The following is a description of a gene set: Human Gene Set: GOBP_REGULATION_OF_CELL_PROJECTION_ASSEMBLY Any process that modulates the rate, frequency, or extent of cell projection assembly. species: Homo sapiens, and this is the list of marker genes: MYO3B, YAP1, ZMYND10, RAP1GAP, NRXN1, LUZP1, CCP110, PALM, RABGAP1, IFT140, P2RX4, EPHA2, ACTR2, HAP1, CYLD, CLRN1, AKIRIN1, TBC1D7, SYNE2, MNS1 (NCBI Gene Id 55329), TBC1D19, MAP4, DMTN, USP6NL, DCDC2, GAP43, RDX, CARMIL2, PODXL, WDPCP, ADAMTS16, COBL, ARAP1 (ArfGAP with RhoGAP domain, ankyrin repeat and PH domain 1), P2RX7, SEPTIN9, CTTN, C15orf62, DYNC2LI1, TBC1D30, EPS8L2, EPS8, AGRN, ANLN, PLPPR5, TBC1D21, TBC1D17, DPYSL3, ODF2, HRG, FUZ, RHOG, FNBP1L, RAB11A, RALA, BBS4, LIMA1, DOCK11, TBC1D20, MIR196A1, ARHGAP35, TBC1D10B, NRP1, WASL, TWF1, TBC1D10A, CROCC, AVIL, CCDC88A, KANK1, NDEL1, TBC1D2B, RAB3IP, ACTR3, FMR1, ARHGAP44, SRF, TRIM32, MAK, TWF2, HSP90AA1, PFN1, CCL19, MPHOSPH9, RAB17, MAPK15, EPS8L3, RAC1, WASHC1, WDR44, CDC42EP1, TBC1D24, KIF24, TBC1D16, EVI5 (ecotropic viral integration site 5), ARPC2, CFL1, SEPTIN7, PIK3CA, ATG5, TBC1D13, EVI5L, FER, CDC42EP3, TESK1, RP1, CDC42, SAXO1, HTT, CLN3, LPAR1, DEF8, DYNLT2B, TBC1D22A, ODAD3, PLEK2, IFT88, TBC1D9B, AUTS2, NEURL1, PLXNB3, ATP8B1, TENM1, ICAM1, CDC42EP2, SRC, TTBK2, PIK3R1, TBC1D10C, TBC1D14, MTOR (mechanistic target of rapamycin kinase), CENPJ, TRPM2, P2RY12, FSCN1, FAM98A, TENM2, WRAP73, OCLN, FAM110C, TGFBR1, CDC42EP5, PLEKHM1, RAC2, F2RL1, FRMD7, ZMYND8, NOTO, BRK1, ARF4, SLIT2, GSK3B, PLD1, STAP1, CDKL1, CEP120, SRGAP2C, CDK10, SH3YL1, LIMK2, CEP97, MARCHF7 (membrane associated ring-CH-type finger 7), TACSTD2, IFT20, EVL, MCIDAS, MSTN, RAB5A, WAS (NCBI Gene Id 7454), CORO1C, AKT1, MIEN1, TCHP, SGSM3, ABITRAM, TBC1D1, WNT1, EPS8L1, MARK4, RIPOR2, RABEP2, PLCE1, ABI3 (ABI family member 3), NCKAP1, PRKCD, CNTROB, CDC42EP4, TGFB3, MYO10, RHOQ, DZIP1, EPHB2, DAAM2, TBC1D15, GPM6A, SDCCAG8, CEP135, TBC1D8, CCL21, ATMIN, WASF2, ODF2L, CAV1, ARF6, RCC2, ATG3, TBC1D2, TBC1D5, TAPT1, NLGN1, TBC1D22B, INTU, PPP1R16B, MYO3A, KIT, HRAS, MIR214, PPP1R35, ABI2, KCTD17, ARHGAP24, TBC1D3, ENTR1, USP17L2, BIN3, CDKL5, CCR7, PFN2, GDI2, APC, CYFIP1, RAB11FIP3, STAU2, KLF5